The following is a description of a gene set: Human Gene Set: GSE3982_DC_VS_MAC_UP In the present study we used Affymetrix oligonucleotide microarrays to produce gene transcription profiles for the major leukocyte types in humans. This comprehensive dataset enabled us to not only establish which genes were expressed in each leukocyte type, but also which genes were expressed in each subset after activation. The used of a comprehensive dataset of gene profiles from all the major human leukocyte subsets enabled a novel and powerful means for identification of genes associated with single leukocyte subsets, or different immune paradigms. species: Homo sapiens from publication Jeffrey KL, Brummer T, Rolph MS, Liu SM, Callejas NA, Grumont RJ, Gillieron C, Mackay F, Grey S, Camps M, Rommel C, Gerondakis SD, Mackay CR (PMID 16474395) Genes up-regulated in comparison of dendritic cells (DC) versus macrophages., and this is the list of marker genes: RESF1, RRS1, VCPIP1, NR4A3, ERCC5, CNGA3, LINC00115, PPP1R16B, TBC1D8, CWC25, CEP112, VCL, IGFLR1, PAX3, ARL4C, MSRB1, HOMER2, ZBTB39, LPAL2, CTNNAL1, ARHGEF6, RUFY1, ITGB1BP2, P2RY6, MYF6, CD1B, RAD50, UBR4, PSG5, PDGFA, CXCR2, CACNA1A, ZKSCAN5 (NCBI Gene Id 23660), SLC35E1, ZNF236, ITFG2, FLT1, MAGOHB, CCL17, MYH3, SPSB3, EDEM1, CFB, DDX43, HDAC9, RAB15, CD226, FHL2, TH, CRYBG3, RNMT, EPS8L1, ZNF350, RITA1, NPEPPS, CCDC92, TFEB, SLC7A1, MIR622, CEP290, ALOX15, KCNE4, TACSTD2, PGAM2, FCER2, SNX3 (NCBI Gene Id 8724), NCF2, CLDN17 (NCBI Gene Id 26285), SYNRG (synergin gamma), VPS4A, NLRP3, FARP1, C1orf50, RBPJ, ACP5, GSTT1, PARN, DHRS11, DNPEP, PTBP1, VPS35L, HSD11B1, TRAPPC4, FAM13C, KDM7A, TAL1, TRAM2, CIRBP, OPN3, IPCEF1, PPBPP2 (NCBI Gene Id 10895), UGP2, H2AC6, GALNT11 (NCBI Gene Id 63917), CYP4F8, ENTPD4, SPTLC3, GABPB1, CMC4, SAP30L-AS1, ANXA11, CDK3, CARD9, CHST12, CARS1, HLA-DQB1, SRI, RIMS3, SRPK2, MALT1, SLCO3A1, CD1E, SHFL, CNOT4, FAM136A, SERPINB10, ITIH1, BBS9, ZNF768, LSR, CRKL, SLC25A36, CAPN3, TGFA, ING1, NFIL3, PFKP, ADIRF, NAIP, COQ8A, PAFAH1B3, SUOX, PGS1, PPP1R3D, SETD3, GUCA1A, DUSP22, LRRFIP2, DPF2, SEC14L5, PRPF4, ANAPC2, REPIN1, MEF2A, GPR25, SERINC2, CYP2A7P1, NFE2L3, RNF13, RFX5, WDR70, IQCB1, POLR3F, NOLC1, NSMCE4A, LAMP3, GLT8D1, FBXO21, NME8, CEACAM5, VTN (NCBI Gene Id 7448), TRIB2, CUL4A, CDCP1, DAP, COMP, IGSF3, C1orf115, GRB10, ZNF516, ABCG2, CXCL11, PRPS1, CSAD, ELMO3, SCGB1A1, REG1CP, CBLL1, SEPTIN2, SOCS1, SRPRA, PCF11, PRMT7, PAPOLG, CHST7, KIR2DL2, TRADD, ARHGAP45, EFHC2, MAP2K4, VAMP1, PTCD1, SLF2, CORO2A, OSBPL1A, TBKBP1 (NCBI Gene Id 9755), DCLRE1C, FAF2, CST4, PGLYRP1 (NCBI Gene Id 8993)